Given this list of marker genes TBL1XR1, PLEKHM1, RHOT1, DSTYK, GNAZ, PIK3R1, XKR6, RAB3B, SOX21, ZDHHC9, RAB10, VNN3P, STC1, ATRX, GRK6, PTMA, CRK, ZNF536, PRIMA1, RALGPS1, CTNNB1, ANAPC1P2, USP20, NFIX, SINHCAF, CHRM1, ERP29, TAB3, CYP4F22, PHF6 (NCBI Gene Id 84438), UBR5, NEXMIF, MBD6, SRPK2, EMX2, MAP1A, NUDT18 (nudix hydrolase 18), JADE2, TAFAZZIN, THTPA, FNBP1L, RARG, PDSS2, CHD9, BAZ2A, RANBP9, KCNA6, SLC10A3, FBXW11, DLGAP2, DDX6, COPZ1, here is a description of the gene set: Human Gene Set: GCTGAGT_MIR5125P studied in species Homo sapiens Genes having at least one occurence of the motif GCTGAGT in their 3' untranslated region. The motif represents putative target (that is, seed match) of human mature miRNA hsa-miR-512-5p (v7.1 miRBase).